Given this list of marker genes NFKB1 (NCBI Gene Id 4790), DKKL1, SNAI1, MALRD1, UGT1A8, PDE8B (NCBI Gene Id 8622), C7orf50, CH25H, REST, MIR27B, INSIG2, APOE, PROX1, ERLIN1 (NCBI Gene Id 10613), DKK3, GFI1, ERLIN2, ATP1A1, MIR185, ABCA2, INSIG1, MIR30C1, BMP5, MIR33A, GGCX, MIR27A, MIR342, NR0B1, FGF19, WNT4, UGT1A1, SCAP, BMP2, SNAI2, MIR98, MIR548P, here is a description of the gene set: Any process that stops, prevents, or reduces the frequency, rate or extent of the chemical reactions and pathways involving steroids. Human Gene Set: GOBP_NEGATIVE_REGULATION_OF_STEROID_METABOLIC_PROCESS studied in species Homo sapiens